Given this list of marker genes Atp9a, Usp7, Eipr1, Lrrk2, Rab29, Arfip1, here is a description of the gene set: Any process that modulates the frequency, rate or extent of retrograde transport, endosome to Golgi. Mouse Gene Set: GOBP_REGULATION_OF_RETROGRADE_TRANSPORT_ENDOSOME_TO_GOLGI studied in species Mus musculus